The following is a description of a gene set: Mouse Gene Set: GOBP_POSITIVE_REGULATION_OF_CALCIUM_ION_TRANSMEMBRANE_TRANSPORT studied in species Mus musculus Any process that activates or increases the frequency, rate or extent of calcium ion transmembrane transport., and this is the list of marker genes: Dbi, Ppp3r1, Drd1, Il13, Strit1 (small transmembrane regulator of ion transport 1), Ppp3cb, Asph, Cxcl10, Xcl1, Atp2a1, Adrb1, Cx3cl1, Npsr1 (NCBI Gene Id 319239), Hap1, P2rx7, Agtr1a, Grm6, Htt (huntingtin), Hspa2, F2, G6pdx (NCBI Gene Id 14381), Pdpk1, Stac2, Ppp3r2, Bmp4, Plcg2, Capn3, Rapgef3, Pkd2, Ehd3, Trpc1, Vmp1, Bdkrb1, P2rx1, Cd4, Stac, Cacna1d, Akap6, Cxcl9, Plp1, Oga, Ank2, Fgf14, Jph2, Clec4b1, Gjc2, Trdn, P2rx4, Cacna1c, Adrb2, Plcg1, Ms4a1, Stim1 (NCBI Gene Id 20866), Grin1, Ppp3cc, Cxcr3, Aplnr, Cacnb3, Ednra, Gimap5, P2rx5, Gimap3, Ntsr1, Stim2, Stac3, Stimate, Trpc3, Ppp3ca, Gsto1, Cd19, Snca, Lhcgr, Ffar1, Gpr39, Bax, Slc9a1, P2ry6, F2r, Sri, Cav1, Gper1, Gstm7, Nipsnap2, Calm1, Adcyap1r1, F2rl3, Calm3, Sumo1, Calm2, Casq1, Cemip, Cxcl11, Abl1, Cacnb2, Akap5, Bak1 (BCL2-antagonist/killer 1), Cracr2a, Thy1, G6pd2